The following is a description of a gene set: species: Homo sapiens Human Gene Set: GOCC_NUCLEAR_SPECK A discrete extra-nucleolar subnuclear domain, 20-50 in number, in which splicing factors are seen to be localized by immunofluorescence microscopy., and this is the list of marker genes: PRPF4, AAGAB, SMU1, HP1BP3, SDE2, ALYREF (NCBI Gene Id 10189), PRPF19 (pre-mRNA processing factor 19), SARNP, MOCS2, STK17A, CLK3, SGK1, HIPK1, SAP18, CHTOP, ERBIN, RBM39, NPM1, RUVBL1 (NCBI Gene Id 8607), GLI3, PRPF40A, CCNL1, BRD2, PRP4K, FAM193B, AFF2, EAF2, CDC25C, AKAP17A, ITPKC, MSX2, NME8, CBX4, PIP5K1A, HDAC5 (histone deacetylase 5), FAM107A, AK6, APEX1, SOX2 (SRY-box transcription factor 2), HSPA1A, USH1G, LPXN, HNRNPU, PLCB1, LMNA, THOC2, THOC7, HIF1A, MEOX2, RNPS1, TOE1, DDX46, SFPQ, MAPK14, CHRNA3, AP5Z1, RMI2, MEF2C, PIAS1, NR0B1, NRIP1, FYTTD1, TENM1 (teneurin transmembrane protein 1), PRPF18 (NCBI Gene Id 8559), FEV, DHX36, GATAD2B, NCAPG2, RFXAP, BNIP3L, ACIN1, SRP54, GLIS2, ZNF217 (NCBI Gene Id 7764), SNRPB2, PIAS2, ZBTB16, EPAS1, NXT1, HSPB6, SRSF4, SCAPER, BASP1, SMURF2, PLA2G6, THOC3, NR1H4, IL15, NSRP1, YTHDC1, METTL3, PAK2, HSPB3, PPP4R3B, PPP1CC, FOXO4, NDC80, ABITRAM, POMP, RBM25, SETD1B, TERT, GATAD2A, KAT6A (NCBI Gene Id 7994), CKAP4, WTAP, U2AF2, CDK13, TFIP11, RSRC1, GCAT, TIMM50, SMC6, TMEM237, PPIG, IFI16, FANCG, RPGRIP1L, ZC3H13, BCLAF1, CACNB4, TCERG1, CBY1, LUC7L2, KMT2E, MBD4, RBM15B, DDX39A, CD2BP2, MSL1, PRCC, HBP1, PPIH, KAZN, POU4F2, PNN, PARN, RCHY1, SRSF11, BANP, RBM14, MECOM, ELL, ABHD17A, ELL3, OIP5, ZNF106 (zinc finger protein 106), CCDC85C, ZC3H14, E2F7 (E2F transcription factor 7), ZC3H11A, WRN, PRPF31, TBXA2R, POLDIP3, AKAP8L, SURF2 (surfeit 2), AFDN, SRPK1, GTF2H2C, PPP4R3A, SLC28A1, TRIM22, PRKACA, POLR2D, ARL6IP4, CASC3, INPPL1, SMC4, IL16, RUFY1, NXF1, ATOH8 (atonal bHLH transcription factor 8), WBP4, EIF4ENIF1, SON, SCNM1, ALKBH5, PHF5A, ZBTB18, PIAS3, ATXN2L, VIRMA, SLC2A4RG, ZNF638, SREK1, NR4A1 (nuclear receptor subfamily 4 group A member 1), RBM8A, CARMIL1, KLF15, ESX1, PQBP1, NONO, SRPK2, EIF4A3, PYHIN1, EHMT2, ATPAF2, CDC34, FIBP, SLC34A1, GADD45A, SART3, SRSF6, TAF5L, BCAS2, CDYL, CRY2, PTPRH, TMEM179B, COPS4, THAP7, YLPM1, ADAMTS4, NSL1, SF3A3, PRPF3, DGKQ, ZNF830, HIF3A, PIN1, REXO4, THRAP3, TRIM69, PHF7, DACH1, POLI, NUP43 (NCBI Gene Id 79700), TCF12, GTF2H4, SRSF7, SAP130, FAM76B, NEK6, EFTUD2 (NCBI Gene Id 9343), HDAC4 (histone deacetylase 4), CWC15, MNS1, GTF2H2C_2, PSPC1, PRPF40B, SF3A1, DZIP1 (DAZ interacting zinc finger protein 1), EAPP, DDX5, PDX1 (NCBI Gene Id 3651), ZC3H18, MAPK9, CCNL2, FAM76A, NCBP3, HEXIM2, RING1, CDC5L, AIPL1, LHPP, IK, ADGRD1, RBM11, SART1, GTF2H2, RBM27, CNOT7, NRDE2, PPIE, APBB1, SNRNP40, CSNK1A1, SNURF, STK19, NR4A2, SERPINB13, GPATCH2, THOC1, CWC22, U2AF1, DDX39B (DExD-box helicase 39B), SFMBT2, SRSF3, SPOP, H2AX, PRKAA2, NDUFB1, PSKH1, DHX15, SRSF12, MAGOH, PSME4, CTR9, SF3B1, PPP1R16B, NAMPT, GRK5, RBM15, SRRM1, SDCBP2, ATF4, DAZAP2, SRSF10, API5, KIF22, DDX17, LUC7L3, CLK2, DUSP11, SNRPA1 (small nuclear ribonucleoprotein polypeptide A'), SNW1, PASD1, SMNDC1, CBLL1, SEL1L2, DYNC2LI1, PLRG1, PLAG1, MAML1, SRY, RBBP6, WAC, MAML3, SIRT7, RNF34, CACTIN, HIKESHI, HABP4, RADX, PALB2, NUGGC, NOC3L, HSF4, FTO, DGKZ, SNURFL, DDX42 (NCBI Gene Id 11325), U2AF1L4, SRSF9, RNF113A, SRSF2, CDC40, HSPA1B, HOXA6, CDK12, SNRNP70, AR, RBM4B, EIF4E, ATP6V0A1, SRSF1, PRPF8, PRKN, DNAJC11, RREB1, NR3C1, RBM10, COP1, SF3A2, PABPN1, SRSF8, PPP1R8, DGKB, MBD1, EP400, BMP2K, UNC45A, VPS72, PACSIN2, UBASH3A, ETAA1, IQCH (IQ motif containing H), NFATC4, SLU7, ASCC3, EPOR, PCBP1, WT1, ARGLU1, PRKAA1, USP36, TARDBP, LIMK1, OGG1, CWC25, MAML2 (NCBI Gene Id 84441), ARHGAP18, C12orf57, SGO1, SMC5, TREML1, SUMO1, MARCKS, RTEL1, SPRTN, TUT1, PRPF6, CYGB, TCIM, ZNF395, TRIP12, RBM4, SRSF5, S100PBP, EAF1, SRRM2, CRNKL1, BRD1, TAP2, TOPORS, ASCC2, JADE1, DYRK3, PNISR, FBXL4, SF3B2, MORF4L1, BAZ2A, PATL1 (NCBI Gene Id 219988), THOC6, CIR1, RBM19, CPSF6, BARD1, CHD5, SETD1A, CXXC1, SYF2 (NCBI Gene Id 25949), ASCC1, MTREX, DYRK1A, ILRUN, RAB11FIP5, DENND1B, NFKBIZ